The following is a description of a gene set: Correlates of immune-mediated protection to most viral and cancer vaccines are still unknown. This impedes the development of novel vaccines to incurable diseases such as HIV and cancer. In this study, we have used functional genomics and polychromatic flow cytometry to define the signature of the immune response to the yellow fever (YF) vaccine 17D (YF17D) in a cohort of 40 volunteers followed for up to 1 yr after vaccination. We show that immunization with YF17D leads to an integrated immune response that includes several effector arms of innate immunity, including complement, the inflammasome, and interferons, as well as adaptive immunity as shown by an early T cell response followed by a brisk and variable B cell response. Development of these responses is preceded, as demonstrated in three independent vaccination trials and in a novel in vitro system of primary immune responses (modular immune in vitro construct system), by the coordinated up-regulation of transcripts for specific transcription factors, including STAT1, IRF7, and ETS2, which are upstream of the different effector arms of the immune response. These results clearly show that the immune response to a strong vaccine is preceded by coordinated induction of master transcription factors that lead to the development of a broad, polyfunctional, and persistent immune response that integrates all effector cells of the immune system. Genes up-regulated in peripheral blood mononuclear cell 3d vs 0d in unknown after exposure to YF-Vax/Stamaril, time point 3D Human Gene Set: GAUCHER_PBMC_YF_VAX_STAMARIL_UNKNOWN_AGE_3DY_UP studied in species Homo sapiens from publication Gaucher D, Therrien R, Kettaf N, Angermann BR, Boucher G, Filali-Mouhim A, Moser JM, Mehta RS, Drake DR 3rd, Castro E, Akondy R, Rinfret A, Yassine-Diab B, Said EA, Chouikh Y, Cameron MJ, Clum R, Kelvin D, Somogyi R, Greller LD, Balderas RS, Wilkinson P, Pantaleo G, Tartaglia J, Haddad EK, Sékaly RP (PMID 19047440), and this is the list of marker genes: FCER1G, BTN3A1, HERC6, SIL1, CCR1, TDRD7, TRIM21 (tripartite motif containing 21), UBE2L6, CTSL, SHISA5, BLVRA, RIGI, IRF7, KIAA0319L, TAP2, IFIT3, IFI27, IFIT1, SCIMP, IFI35, SRC, IFI16, LAP3, ATF5, TENT5A, RSAD2, ISG15, EIF2AK2, C3AR1, CASP1, IFIH1, TICAM1, ADA2, LGALS9, IFI6, UBA7, NRROS (NCBI Gene Id 375387), TRIM22, SERTAD1, MT2A, PLAGL2, IFIT2, FFAR2, HAVCR2, HLA-A, SCARB2, TIMM10, SAMD4A, PLSCR1, GNA15, ZNFX1, STAT2, MYOF, MAD2L1BP, RNH1 (ribonuclease/angiogenin inhibitor 1), DRAP1, OAS2, HES4, DHRS9, OGFR, OASL, RGL1, DUSP5, CST3, TNS3, RNF31, IFITM1, SCO2, PSME2, RIN2, HK3, GLMP, CDKN1C, PARP14, GORASP1, CD86, TLR7, CSRNP1, C1QB, IFI44L, RAB8A, IFITM3, TAGLN, MYD88, RNF135, JUP, CD300C, PARP12, APOBEC3A, RIPK3, ADAR, TTC38 (NCBI Gene Id 55020), CSF1R, CX3CR1, EPB41L3, ZBP1, IFI44, CYSLTR1, MT1F, SMCO4 (single-pass membrane protein with coiled-coil domains 4), SRBD1, CNDP2, PARP9, SIDT2, SERPING1, REC8, TRAFD1, TNFSF10, LILRB1, FRMPD1 (FERM and PDZ domain containing 1), AIM2, NTNG2, PCK2, GNGT2, MS4A7, RBCK1, ABI3, TTYH3, SLC27A3, IDH2, TOR1B, MARCO, DHX58 (DExH-box helicase 58), NPC2, NAGK, SEPTIN4, SP110, NAGA, ASCL2, STAT1, TCN2, ALDH3B1, SP140, SAMD9L, PARP10, NAPA, TAP1, SUSD1, SLC3A2, SIGLEC5, MX2, LHFPL2, FLVCR2, TMEM268 (NCBI Gene Id 203197), C1QA, OAS1, IFI30, DDX60 (NCBI Gene Id 55601), SLC2A6, TRIM5, IL1RN, CDKN1A, PHF11, IRF9, HELZ2, IFIT5, TMEM62, OSBPL5, RRAS, TRIM26, ABCA1, APOBEC3F, CD68, ANKFY1, ASPRV1, MT1A, PTGDS, HERC5, GIMAP8, PSME1, ZFYVE26, CAMK1, TYMP (NCBI Gene Id 4334), TRIM38 (tripartite motif containing 38), DPYSL2, SNTB1, XAF1, KCNMB1, HMOX1, BST2, TMEM123, LY6E, OTOF, TNFSF13B, WARS1, ADA, MICB, LMO2, NUB1 (NCBI Gene Id 51667), GADD45B, CEACAM1, LYPD2, SORT1, GALM, SPATS2L, SLC37A2, CYBB, ADAP2, MOV10, MX1, ACOT9, EPSTI1, AP5B1, RHBDF2, RTP4, ZC3HAV1, FBXO6, GRN, PRAM1, PLAC8, FCN1, TMEM140, LGALS3BP, MAFB, GBP1, RGS12 (NCBI Gene Id 6002), SHFL, OAS3, GPBAR1